The following is a description of a gene set: Any process by which the number of skeletal muscle satellite cells in a skeletal muscle is maintained during muscle regeneration. There are at least three mechanisms by which this is achieved. Skeletal muscle satellite stem cell asymmetric division ensures satellite stem cell numbers are kept constant. Symmetric division of these cells amplifies the number of skeletal muscle satellite stem cells. Some adult skeletal muscle myoblasts (descendants of activated satellite cells) can develop back into quiescent satellite cells, replenishing the overall pool of satellite cells. species: Mus musculus Mouse Gene Set: GOBP_SKELETAL_MUSCLE_SATELLITE_CELL_MAINTENANCE_INVOLVED_IN_SKELETAL_MUSCLE_REGENERATION, and this is the list of marker genes: Igf1, Wnt7a, Fzd7, Ezh2, Selenon